Given this list of marker genes P2ry2, Ttf1, Adra2c, Sftpc, Zdhhc2, Sftpa1, Adora2a, Napsa, Dmbt1, Lmcd1, Adora2b, Slc34a1, Adra2a, Adgrf5, Ccdc59, Sftpb, Ctsh, Gata6, Sftpd, Abca3, Slc34a2, Ckap4, here is a description of the gene set: Mouse Gene Set: REACTOME_SURFACTANT_METABOLISM Surfactant metabolism studied in species Mus musculus